Given this list of marker genes COP1, UBB, PSMB1, PSMD7, PSMA5, PSMA2, PSMD6, CCNE2, PSMD2 (proteasome 26S subunit ubiquitin receptor, non-ATPase 2), PSMC2, MDM2, PSMA4, PSMD13, PSMA6, RPS27A, PSMA7, PSMC1, PSMB4, CCNE1, PHF20, CDC25A, PSMB3 (proteasome 20S subunit beta 3), PSMD3, PSMA3, UBA52, PSMC3 (NCBI Gene Id 96121), UBC (ubiquitin C), MDM4, CCNA2, ATM, CCNA1, CDK2, PSMA1, CHEK2, PSMD8, PSMD14, CHEK1, PSMC6, CDKN2A, PSMD11, PSMC4, PSMB2, ZNF385A, PSMB7, PCBP4, PSMD12, SEM1, PSMB5, PSMD1, CDKN1B, CDKN1A, ADRM1, TP53, PSMB6 (proteasome 20S subunit beta 6), PSMC5, here is a description of the gene set: G1/S DNA Damage Checkpoints Human Gene Set: REACTOME_G1_S_DNA_DAMAGE_CHECKPOINTS studied in species Homo sapiens